The following is a description of a gene set: Aplasia or Hypoplasia affecting the 5th metacarpal. Human Gene Set: HP_APLASIA_HYPOPLASIA_OF_THE_5TH_METACARPAL Aplasia/Hypoplasia of the 5th metacarpal species: Homo sapiens, and this is the list of marker genes: SMC3, PRKG2, NOG, ERI1, FGF16, BMP2, HOXD13, COL11A2 (NCBI Gene Id 494120), SVBP (NCBI Gene Id 374969), TBX3, LBR, RUNX2, SRCAP, FERMT1, FLNA, GNAS